The following is a description of a gene set: Recurrent Neisserial infections studied in species Homo sapiens Recurrent infections by bacteria of the genus Neisseria, including N. meningitidis (one of the most common causes of bacterial meningitis). Human Gene Set: HP_RECURRENT_NEISSERIAL_INFECTIONS, and this is the list of marker genes: C6, C5, C7, MBL2 (mannose binding lectin 2), CFB, CFI (complement factor I), C8B